The following is a description of a gene set: OAS antiviral response studied in species Mus musculus Mouse Gene Set: REACTOME_OAS_ANTIVIRAL_RESPONSE, and this is the list of marker genes: Abce1, Pde12, Rigi, Rnasel, Oasl1